The following is a description of a gene set: studied in species Homo sapiens Genes predicted to be targets of miRBase v22 microRNA hsa-miR-550a-3p in miRDB v6.0 with MirTarget v4 prediction scores > 80 (high confidence targets). Human Gene Set: MIR550A_3P from publication Chen Y, Wang X (PMID 31504780), and this is the list of marker genes: THBD, TTLL7, C1orf94, ZNF14 (zinc finger protein 14), JMY, MAPK6, MBLAC2, CMIP, SEMA4F, PHACTR2, MSRB3, PCDH17, MEAF6, COL11A1, ZBTB8A, POTEF, CPEB2, IRAK1BP1 (interleukin 1 receptor associated kinase 1 binding protein 1), IL7, MYT1L, PTGIS, HECA, SLC16A14, DCDC2, PGPEP1L, TPRG1L, GNAI3, PSMD14, PLEKHF2, SMAD5, INA, CNIH1 (cornichon family member 1), HTR2C, HEPHL1, ZNF792, SERINC5, PLXDC2, GARIN2, SYT4, POTEM, VTI1A, EML1, CCNT1, HIVEP1, PITPNC1, ARID4B, PTBP3, CASQ2, HS3ST3B1, C19orf44, HOXA4, ZDHHC15, MTM1, DTNA, GNG13, CD47, SMARCD2, CAPRIN1, SLC25A13, SLC16A7, TDP1, RAP1A, MAP1B, ATP1A2, CAVIN2, CMAS, MYH10, UTP15, IRS1, VASN, GNAO1, ZNF763, SYNCRIP (synaptotagmin binding cytoplasmic RNA interacting protein), ZSCAN18, PAK3, MLANA, CPXCR1, PCDH8